The following is a description of a gene set: Human Gene Set: GSE15659_CD45RA_NEG_CD4_TCELL_VS_ACTIVATED_TREG_DN Gene expression profiles of subsets of CD4+ T cells according to their expression of FoxP3 and CD45RA were compared. FoxP3 is a key transcription factor for the development and function of natural CD4+ regulatory T cells (Tregs). Here we show that human FoxP3+CD4+ T cells are composed of three phenotypically and functionally distinct subpopulations: CD45RA+FoxP3low resting Tregs (rTregs) and CD45RA-FoxP3high activated Tregs (aTregs), both of which are suppressive in vitro, and cytokine-secreting CD45RA-FoxP3low non-suppressive T cells. The proportion of the three subpopulations characteristically altered in cord blood, aged individuals, and patients with immunological diseases. Terminally differentiated aTregs rapidly die while rTregs proliferate and convert into aTregs in vitro and in vivo as shown by the transfer of rTregs into NOD-scid-common gamma-chain-knockout mice and by TCR sequence-based T cell clonotype tracing in peripheral blood of normal individuals. Taken together, the dissection of FoxP3+ cells into subsets enables one to analyze Treg differentiation dynamics and interactions in normal and disease states, and to control immune responses through manipulating particular FoxP3+ subpopulations. Genes down-regulated in comparison of PTPRC- CD4 T cells versus activated regulatory T cell (Treg). species: Homo sapiens from publication Miyara M, Yoshioka Y, Kitoh A, Shima T, Wing K, Niwa A, Parizot C, Taflin C, Heike T, Valeyre D, Mathian A, Nakahata T, Yamaguchi T, Nomura T, Ono M, Amoura Z, Gorochov G, Sakaguchi S (PMID 19464196), and this is the list of marker genes: RD3, RTN4, SHISA6, PPP2R5A, TTL, SSR2, KRBOX5, UBL7, PSMA2, ZC3H13, PLEKHM3, ZNF316, STX16, SNORA65, UBE2U, ZNF131, VCPIP1, TAS2R9, SDCCAG8, TNFSF12, PLK4, RRM1, SF3B1, THAP1, UTP11, STARD3, RNF150, ZNF394, SEMA6A, ST7-AS1, EMC4, TBC1D4, GFUS (NCBI Gene Id 7264), RNF113A, TCP10L3, UBL3, TUSC2, TRIML1, DNAAF10, THRB, TRAPPC6B, PRKAG3, SLC43A3, SEC14L1, TPSAB1, PNPT1, TRIP12, DENND2B, SMG5, ZNF200, STARD4, STK32A, PLPP5, SMAP2, SETD1B, RPL26L1, SARS2 (NCBI Gene Id 59279), SMAD1, POLD4, PRMT3, UBA6, HACD4, TMCO6, SLC35F3, RHBDL2, STX10 (NCBI Gene Id 8677), SLC25A2, TMEM208, ZAN, RSPH1, SOX2-OT, TTC12, TPMT, STK25, TMEM97, SLC9A8, ZMIZ2, YIPF2, YPEL5, TOP3A, TINF2, UGT2B17, USP43, SPATC1, PRDX3, TLR4, ZNF687, PLEKHH3, SLC25A3, YY1, RGS17, POLR1H, PSMG2, SNAP91, SRL, RTP1, STK16, STXBP5L, TIFAB, SLC41A1, PPP4R2, RPAIN, WARS1, WDR33, SPDYA, ZNF663P, PLIN5, ZCCHC9, SAP30BP, SCN8A, ZDHHC8BP, RAB2B, POP7, SUMO4, S1PR2, SPATA22, RNF10, SEPTIN3, TUBB4B, TRIP6, SLC35E2A, SEMA4A, ZNF530, RSPH10B2, TUBGCP3, RAB11FIP4, SAMSN1, SEC24D, UBA3, RAMP1, USP34, SNED1 (NCBI Gene Id 25992), TTTY13, SLC43A2, TCEAL8, PROM1, RABGAP1, SLC16A4, STING1, TPR, UBE2J1, UBR3, SDC3, NECTIN4, GET1, RHOH, RNF214, ROCK1, SHMT2, SLC4A2, SLC39A1, ZSCAN29, PPP1R13L, RENBP, PSRC1, SKI, ZCCHC13, PLIN4, SH2D1A, S100P, SEC23B, ROPN1B, ZNF385D, ZFC3H1, SYN2, PRDM1, SGO2, TFF2, TMSB4Y, TIMM17A, TP53INP2, ZNF596, TGM6, PROCR, TRIM16, ZNF747, TRPM6, ROS1, PYHIN1, TYSND1, SAP18, SLC8B1, SLC45A1, PLCB2, USP11, RGS4, TOR1AIP1, SEPHS2, RAB8B, SCARF2, SCO2, SLC4A9, WDR91, THBS2 (thrombospondin 2), AMH, RPS6KB2, EIPR1, PPP2CA (protein phosphatase 2 catalytic subunit alpha)